Given this list of marker genes THUMPD2, GSTA3, CLEC4D, ARRDC4, DIP2A, LRRC58, ZNF318, KIF21B, CDK5 (NCBI Gene Id 1020), AKAP1, NDEL1, LAYN, GRINA, CRAT, LRRC42, FKBP14, FGD3, SRXN1, CTNS, CHKA, CEP57, ALKBH7, DNAAF10, CCDC93, OSGIN1, LYPD6B, GABARAP, ZSWIM1, MRPS31 (mitochondrial ribosomal protein S31), PLEK, ZNF512B, FADD, SIRPA, FAM8A1, COQ10A, LTBR, ANKRD13D, BRD3, LBP, SAR1B, MIGA1, CBR3, DCAF5, FOXJ3, TRIP6, SMIM29, MTCH1, CBL, SH3TC1, LATS2, DEXI, ZWINT, PDLIM4, RIOK3, TMED2, TGIF1, IMPDH1, TRIM24, SLC43A2, FBXO31, CTSD, BNIP1 (NCBI Gene Id 662), SRSF2, STAC2, KDSR, AGO2, PGP, BRWD1, ARL8A, ITPRIPL1, TMEM165, USP36 (ubiquitin specific peptidase 36), ARHGAP22, CD14, LPCAT1, PON2, ILK, SLC27A1, ZFAND2A, MSN, RAB14, RNF128, RING1, BBS7, PRDX1, VAPB, AKAP8L, AAK1, LONRF3, DTNBP1 (dystrobrevin binding protein 1), METTL17, KAT6B, FKBP8, SAMD8, EIF3A, MSTO1, MMP12, MRTFA, STOML2, CTBP2, PRKAB2, CWC15, ARHGAP39, ADO, PYCR2, IRF3, LHPP, RWDD1, ASB6, FAM13A, SLC22A4, FAM174A, ATP6V1G1, NT5C3B, RABL2A, ABTB1, CPNE2, SORT1, CAV2, POP1, DCTN6 (NCBI Gene Id 10671), CUTA, SPSB2, GNAQ, LDB1, MAPK14, MINK1, HS1BP3, SLC25A30, MPV17L2, KIAA1328, LRRC75A, RAB35, PPP1R27, EEF1G, DTX4, TMEM9, PIAS4, APH1B, SLC6A15 (solute carrier family 6 member 15), ZNF670, FAM110A, RAB38, IGF2R, NFYA, TOM1, CD9, MPHOSPH10, CDADC1, DCTN2, RPL36 (ribosomal protein L36), MAP4K5, SH3BP5L, NMT1, CARD9, TADA1, ATP5MF, PLIN2, MRPL36, TBC1D17 (NCBI Gene Id 79735), COX5B, PPIC, THUMPD1, NMRK1, PHF7, SRFBP1 (NCBI Gene Id 153443), CEBPA, FBXO6, RAPGEF1, DISP1, PUSL1, MAP2K2, CSNK2B, ATP23, MFSD5, DPP7, here is a description of the gene set: Genes down-regulated in monocytes (6h): untreated versus M. tuberculosis 19 kDa lipopeptide. from publication Schenk M, Krutzik SR, Sieling PA, Lee DJ, Teles RM, Ochoa MT, Komisopoulou E, Sarno EN, Rea TH, Graeber TG, Kim S, Cheng G, Modlin RL (PMID 22447076) Human Gene Set: GSE34156_UNTREATED_VS_6H_TLR1_TLR2_LIGAND_TREATED_MONOCYTE_DN species: Homo sapiens human blood monocytes were isolated, activated and harvested at several timepoints In this study, we identified genes that were differentially expressed in human monocytes activated with eiter NOD2L and/or TLR2/1L.